Given this list of marker genes UPF1, NMD3, SMARCE1, YAP1, SAMD5, ST6GAL1, TAF7, TCF7, ZNG1C, ZNG1F, CCNB1, ACVRL1, ADCY1, WNK3, CCDC83, ZMYM2, ALG10B, ZRANB1, AKIRIN1, KPNA3 (NCBI Gene Id 3839), CFAP210, KRTAP3-2, ATL1 (NCBI Gene Id 6681), ZNG1A, FOXA3, RAB14, ZC3HAV1, MKRN1, XRCC2, RRN3, FCRL1, DMAC1, ZNG1E, OSBP, EPHA7, CDH18, PBX1, VPS54, CLCN5, USF3, TM9SF3, ANKRD34A, NCOA7, SCN1A, MRPL35, SETD6, ZNG1B, ASIC1, ASH1L, JAGN1, VAV2, KANSL1L, ALG10, RALA, ANKH, LNPK, PMPCB, SCARB2, HMGA2, MYCN, CWC25, here is a description of the gene set: Genes predicted to be targets of miRBase v22 microRNA hsa-miR-3130-5p in miRDB v6.0 with MirTarget v4 prediction scores > 80 (high confidence targets). studied in species Homo sapiens from publication Chen Y, Wang X (PMID 31504780) Human Gene Set: MIR3130_5P